The following is a description of a gene set: Human Gene Set: GOBP_MAINTENANCE_OF_APICAL_BASAL_CELL_POLARITY species: Homo sapiens Retaining the established polarization of a cell along its apical/basal axis., and this is the list of marker genes: WDR1, ANK1, NHERF1, WNT11, PDCD6IP, LHX2, CRB2